Given this list of marker genes Yes1, Igll1, Fgr, Fyn, Syk, Cd3g, here is a description of the gene set: Reactome Pathway: FCGR activation This event has been computationally inferred from an event that has been demonstrated in another species.<p>The inference is based on the homology mapping from PANTHER. Briefly, reactions for which all involved PhysicalEntities (in input, output and catalyst) have a mapped orthologue/paralogue (for complexes at least 75% of components must have a mapping) are inferred to the other species. species: Mus musculus electronically inferred by orthology from the curated human pathway part of: Fcgamma receptor (FCGR) dependent phagocytosis